The following is a description of a gene set: Prolactin (PRL) is a hormone secreted mainly by the anterior pituitary gland. It was originally identified by its ability to stimulate the development of the mammary gland and lactation, but is now known to have numerous and varied functions. Despite this, few pathologies have been associated with abnormalities in prolactin receptor (PRLR) signaling, though roles in various forms of cancer and certain autoimmune disorders have been suggested. A vast body of literature suggests effects of PRL in immune cells but PRLR KO mice have unaltered immune system development and function. In addition to the pituitary, numerous other tissues produce PRL, including the decidua and myometrium, certain cells of the immune system, brain, skin and exocrine glands such as the mammary, sweat and lacrimal glands. Pituitary PRL secretion is negatively regulated by inhibitory factors originating from the hypothalamus, the most important of which is dopamine, acting through the D2 subclass of dopamine receptors present in lactotrophs. PRL-binding sites or receptors have been identified in numerous cells and tissues of adult mammals. Various forms of PRLR, generated by alternative splicing, have been reported in several species including humans.<br><br>PRLR is a member of the cytokine receptor superfamily. Like many other members of this family, the first step in receptor activation was generally believed to be ligand-induced dimerization whereby one molecule of PRL bound to two molecules of receptor. Recent reports suggest that PRLR pre-assembles at the plasma membrane in the absence of ligand (Gadd & Clevenger 2006, Tallet et al. 2011), suggesting that ligand-induced activation involves conformational changes in preformed PRLR dimers. <br><br>PRLR has no intrinsic kinase activity but associates with Janus kinase 2 (JAK2) which is activated following receptor activation. JAK2-dependent activation of JAK1 has also been reported. It is generally accepted that activation of JAK2 occurs by transphosphorylation upon ligand-induced receptor activation, based on JAK activation by chimeric receptors in which various extracellular domains of cytokine or tyrosine kinase receptors were fused to the IL-2 receptor beta chain (see Ihle et al. 1994). This activation step involves the tyrosine phosphorylation of JAK2, which in turn phosphorylates PRLR on specific intracellular tyrosine residues leading to STAT5 recruitment and signaling, considered to be the most important signaling cascade for PRLR. STAT1 and STAT3 activation have also been reported as have many other signaling pathways; signaling through MAP kinases (Shc/SOS/Grb2/Ras/Raf/MAPK) has been reported as a consequence of PRL stimuilation in many different cellular systems (see Bole-Feysot et al. 1998) though it is not clear how this signal is propagated. Other cascades non exhaustively include Src kinases, Focal adhesion kinase, phospholipase C gamma, PI3 kinase/Akt and Nek3. The protein tyrosine phosphatase SHP2 is recruited to the C terminal tyrosine of PRLR and may have a regulatory role (Ali & Ali 2000). PRLR phosphotyrosines can recruit insulin receptor substrates (IRS) and other adaptor proteins to the receptor complex.<br><br>Female homozygous PRLR knockout mice are completely infertile and show a lack of mammary development. Hemizogotes are unable to lactate following their first pregnancy and depending on the genetic background, this phenotype can persist through subsequent pregnancies. Reactome Pathway: Prolactin receptor signaling part of: Cytokine Signaling in Immune system studied in species Homo sapiens, and this is the list of marker genes: STAT5B, GHR, SKP1, PTPN11, CSH1, RBX1 (NCBI Gene Id 9978), GH1, BTRC, STAT5A, JAK2, GH2, CUL1, PRL, SH2B1, PRLR